Given this list of marker genes TRAPPC6A, TAB1, NEU1, GDF9, CDH17, CIPC, VPS4B, KLHL18, TXN2, CIT (NCBI Gene Id 11113), HNRNPUL2-BSCL2, GINS1, KHDRBS1, ACTL6A, ENSG00000260830, RUVBL1, EIF2B2, LINC02313, BTBD10, SP4, TNKS1BP1, SRP54, VPS39, TMEM170A, SLC26A2, UBE2Z, COPS5, PHF23, PPP1R13L, ANGEL2, PDE4A, CLCN3, ARFIP2, GPR63, PWWP2A, MRPL27, ZNRD2-DT, KDM4B, KLHL20 (kelch like family member 20), FAM83D, RNU6-1276P, KAZALD1, SMARCAD1, COLGALT1, SPNS1, PARK7, OSTC, DUS2 (dihydrouridine synthase 2), DDIT4, ZBTB22, CNEP1R1, TARDBP (TAR DNA binding protein), TOMM40L, FUZ, PCM1, RNH1, XPO1, CHD4, KBTBD4, GMNN, RPL10, MTARC2, PHF20, SUCLG1, SIRT4, SLC16A1-AS1, EXOSC8, SLC30A5, MTHFD2, DERL2, ATP5F1A, H2AC13, TAOK3, NAPRT, HNRNPUL2, GPR108 (G protein-coupled receptor 108), PCBP1, HSD11B1L, TSACC (TSSK6 activating cochaperone), TPI1P2, AP1M2, MBTD1, KPNA6, RBM15, WWP2, KCNIP2-AS1, SPRY4, ERH, MSL2, AP4M1, ZBTB3, GARIN5A, RNGTT, ZNF484, SGO1-AS1, ZNF823, SNAP23, CPSF2, ZSWIM4, GCLC, ACTN4, METTL15, LMAN2L, FGFR1OP2, SNRNP35, MED18 (NCBI Gene Id 54797), PMEL, H2AC25, TBP, ZNF785, TAMM41, STAG3L4, ZNF628-DT, BORA, DDX39B, RPAP3-DT, FBXL12, AFG1L, MKKS, FIBP, IL4I1, MVK, DHX34, EVI5L, MST1, SLC27A5, A2ML1, NFYA, GSPT1 (G1 to S phase transition 1), ACP6, PCK2, GABPA, MBOAT7, ZNF860, ZDHHC6, RNVU1-14, ORC2, FBXO8, FBXL18, AREG, SON, PARL, UTP18 (UTP18 small subunit processome component, NCBI Gene Id 51096), NOP16, HARBI1, FGD5-AS1, MTOR, TNPO3, HECTD1, DCTPP1, DDX39B-AS1, LINC02541, RNPS1, NT5C3A, AMN1, GAPDHP25, ELL3, H2AX, H2BC13, EPB41L5, IKZF4, NXN, PPP6R1, HAUS4, C15orf40, PPP2CA-DT, TIPARP, SPC25, DEPDC1B, ATP5MC3, LINC02363, NDUFA2, PSMD4, YARS1, RBM6, PRKCI, MEMO1, LINC02832, PDCD4, NDUFC1, TMEM87B, DUSP12, DNAJC27-AS1, H2AC11, SFSWAP, MIR762HG, FAM185BP, RRP15, POLG-DT, HOXA-AS3, AGAP2-AS1, POLR2H, LINC01089, TMEM208, TAGLN2, TARS1, R3HDM2-DT, ASTE1, MST1P2, DDIAS, RAB4B-EGLN2, TUBGCP6, HASPIN, CD164, NFATC4, TDRKH-AS1, PMS2P4 (PMS1 homolog 2, mismatch repair system component pseudogene 4), IER3-AS1, CDC37, DOHH, ZDHHC17, WDR74, ABHD17B, PBX3, WDR37, NUBP2, NOSIP, QTRT2, ITGA6-AS1, SLC52A3, POLR3A, CKAP5, RBM7, MAN1B1-DT, GNL1, STYX, DIAPH1-AS1, THBS4, CCNL1, AP1M1, RNU4-2, SMIM31, TIAL1, MAP4, BNIP1, TAX1BP1, SPRED2, MCTP2 (multiple C2 and transmembrane domain containing 2), SZT2, GART, RTRAF, UNC13D, DNMT1, PLSCR4, HMGB2, MPLKIP, HSP90B1 (NCBI Gene Id 7184), RGS5 (NCBI Gene Id 8490), FLOT1, MIS18BP1, UBE2D3, DNAJC27, TAF10 (TATA-box binding protein associated factor 10), EIF3D, VPS26B, NDUFS3, PRELID3BP5, LGALS8, CDIPT, RTN4 (reticulon 4), AK2, EDC3, PROSER1, TSPAN8, VCL, ABCA7, DDX20, BRPF1, SNX10-AS1, NCK1 (NCK adaptor protein 1, NCBI Gene Id 4690), DTWD1, STARD5, HBS1L, ATG4C, MBLAC2, METTL4, UPP1, PRKRIP1, MIR3677HG, CLASP1, TIMM21, ANKHD1, ANKHD1-DT, PSMD7, HSD17B4, TANC1, BORCS5, CASZ1, CLN3, PPP3CA, TOP2A, NDUFA6, PSMD8, CMSS1, RABGAP1L-DT, SOX2-OT, GHDC, FBXW7, PGS1, CDC20-DT, DPH5-DT, SND1-DT, TJP3, H4C2, SPAG5-AS1, KIF18A, SCAMP1, INTS13, NAA15, LIMA1, CCDC30 (coiled-coil domain containing 30), TULP3, RPUSD4, THAP7 (THAP domain containing 7), MTBP, EIF6, DRAIC, SPTLC2, TIMM22, FAM53C (family with sequence similarity 53 member C), SAR1A, MED17 (mediator complex subunit 17), DCP1A, AASDH, ATP5PF, SLC37A1, POLR2M, GTF2B, SMG5, SPSB3, FLAD1, DCLRE1A, ARPC5L, AKR1A1, IGFL2-AS1, TAS2R14, PIGO, WBP11, NR6A1, RAPGEF6, ABCF1, CENPF, NUCKS1, NCOR1, S100PBP, BANP, ANKRD27, HAUS5, MCCC1, ATF3, EIF3F (eukaryotic translation initiation factor 3 subunit F), CCDC9, ZNF446, LOH12CR2, CDCA2, EFHC1, NUP93, NCK1-DT, TMEM198B, NDUFB1, HSDL2, GON4L, ARMH1, QRICH1, KITLG, CAGE1, PSMC3, ARHGAP11A-DT, HNRNPL, MYCBP2, RPRD2, UGT2B7, SRRM2-AS1, ARNT, PLAC8, MYG1 (MYG1 exonuclease), COL17A1, IFNAR1, SETD1A, ACLY, EIF1, ENSA, CLINT1, VTRNA1-2, MAGI1, GRHPR, OXSR1, EME1, UBE2H, ABCA15P, ITFG2-AS1, TMEM218, CDK5, MFAP3, LRR1, ENSG00000268460, HIF1AN, DNAJC19 (NCBI Gene Id 131118), SCAMP2, RPAP3, SUGCT, UBOX5, SPATA17, GPR19, L3MBTL2, KCTD9, BLOC1S1, CRELD1, ANP32A, TXNDC12, TRIM37, BZW1, FADS1, MCTS1, FBXL9P, MOK, SPAG7, GGPS1, COA1, RAD51AP2, GRK6, POLG, CEP89, ZFC3H1, MIR4512, RBM15-AS1, H2AZ1-DT, MRPL24, CCT3, DUS4L, CCDC124, KIFC1, SNORA21, ADGRE2, LAMP1, FKBP2, MIR933, TRAPPC4, CEP350, MIR4999, INO80C, CSPP1, TPX2 (TPX2 microtubule nucleation factor), ILF3 (NCBI Gene Id 54783), ORMDL1, UBXN7, AIRIM, LMBRD1, FAAP24, GDAP1, ERP29, CLRN3 (clarin 3), TCP11L2, TUBA1B, ZNF584, UBALD2, CAPZA2, GIN1, PBX3-DT, ERAP1, H3C1, DHX8, RBM27, BUB1B, MRTFA, SPAG5, PSMD7-DT, PCGF1, ARMT1, CROCCP2, MXD3, DPH5, TMEM79, CDK13, SNORD12, BCL2L14, LEKR1, RHOQP1, RNF186-AS1, JARID2, ELOF1, LENG8-AS1, MRPL45P2, IER5, PSORS1C1, PUS1-AS1, ILF3-DT, FAM47E, PCLAF, LRP4-AS1, HMGCS1, RBMS2, INTS10, RGS9BP, RWDD1, KHSRP, RPL13A, CENPBD2P, CDCA7L, ZNF627, BRF1, SGO1, MEX3C, ARAP1, EWSR1, STARD10, ISOC2, UNC45A, CACTIN, NFATC2IP, RBAK, BUB3, QNG1, BTF3L4, FGFR4, MIR638, CCDC146, KRT8, DOCK8-AS2, HAX1, TMED4, OS9, STX3, EIF5A2, MEST, TBX3, CEP131, PEX12, USP35, SLC39A9, RPH3AL-AS2, PIGN, VTI1A, RBPJ, INTS2, SLC25A42, MRPL13, C12orf60, CDKN2C, ZNF48, EXOC8, FOXA3, NR2C2, LZIC, RPS29 (ribosomal protein S29), MINDY2-DT, LINC00649, TYW1B, SLC2A1, RAB11B, RPL36 (ribosomal protein L36), PRR15L, CMC2, VARS2, THUMPD3-AS1, KDM4C, HDAC5, IWS1, CENPE, MGAT1, RPS6, CCDC163, PDE11A, NDC80, TFPT, ADK, TMUB2, ATP6V0D1-DT, TOM1L2, TAF12, TDRKH, COX6C, TIPRL, NLK, ITPRIP (inositol 1,4,5-trisphosphate receptor interacting protein), CCDC192, ALG5, HEXA, C9orf85, GATAD2A, C14orf119 (chromosome 14 open reading frame 119), HGS, MZF1, ANAPC15, NHLRC3, ZNF786 (NCBI Gene Id 136051), LINC01023, RSRC1, ZNF398, TEF, MROH8, CCT6A, SNED1-AS1, H4C8, TOMM22-DT, ALDOA, IP6K1, VPS39-DT, TEX2, LENG8, ITPA, NPTN, USPL1, DCAF7, TMEM102, RBFA, WDR55 (WD repeat domain 55), TMEM202-AS1, ENC1 (NCBI Gene Id 8507), ALDH4A1, UGP2, FRAT1, ERCC1, LRPPRC, ATP6V0D1, CHM, PMF1-BGLAP, ZNF672, PSME2, CSNK2B, POMP, RABGAP1L, RPL5, MIA2-AS1, TMEM165, CLPTM1, B4GALT3, ELP2, UBE2B (ubiquitin conjugating enzyme E2 B), H2BC11, TMEM53, LRP10, R3HDM2, PRR3, PIH1D2, FAM13B, RIOK1, RPL30, TUFT1, RIC8B, EIF4G2, RIDA, ASCC1, KLHDC10, RPL22L1, PIK3R3, KCNIP2, POLR3G, MRPL49, GTF3C2-AS2, TMED1, SYNGR4, DNAH2, PPP4R3B-DT, MAPK7, DEPDC4, ZNF56P, KCTD7, ITGB8, USP53, TTC9C, CDC40, RGS16, H2AZ2-DT, PRORSD1P (prolyl-tRNA synthetase associated domain containing 1, pseudogene), THRAP3, TICRR, HYCC2, NDUFA3, CCDC191, ZWINT, MIA2, DMXL2, SPECC1, SEH1L, SLC30A9, MED8, TMEM143, EFNA4-EFNA3, UFD1, NGRN, KIF3B, SRP54-AS1, TIMM50, ZNF709, RPL7P30, ZNF514, NEAT1, COMMD6, RBAK-RBAKDN, PSMB10, CYTH2, ANKRD24, TUT7, ENSG00000275740, CDK12 (NCBI Gene Id 51755), ARHGAP19-SLIT1, UBP1, UBL3, PISD, MIR3678, PRCP, TMEM18, CARD8, NOCT (NCBI Gene Id 25819), TPK1, PLK2, BTF3-DT, PMS1, MTMR12, MMUT, PAK4, ABCF2, PFKM, HTD2, COG3, DDA1, CEP120, DDX59, EMP1, PSMD3, RSL24D1, GAR1-DT, TMT1B, SCP2, PLK1, NHLRC2, DMAP1, EIF2B5, PDE12, MARS2, PPOX, CDCA5, PKIA, XRCC2, ANKHD1-EIF4EBP3, CYRIB, POLR1G, NCOA3, HNRNPC, DRC3, ZNF747 (zinc finger protein 747), PPP1R15A, RN7SL688P, RSBN1 (NCBI Gene Id 54665), CBX8, SH3RF2, XAB2, OAZ2, WEE2-AS1, NDUFB3, ATG13, HYAL2, BDNF-AS, RSPH1-DT, SNORD59A, BTN2A1, DHX16, RPL27, SPRYD4, RNF139-DT, MTMR10, CDKN3, KAT6B, SUN1, E2F6, YWHAQ, SP2, ATP5PO, PABIR1, TYK2, SUPT16H, MMAB, INO80E, SSBP1, RAB3A, SNRPD2, CENPQ, ANAPC16, MFSD11, SLC39A6, RAB5B, RNF139, CCDC25, ARL6IP1, C18orf32, UTP3, TUBA1C, SLC50A1 (solute carrier family 50 member 1), RRM2, IK, INCENP, CISD3, SMARCAD1-DT, EXO1, HDGF, B3GALNT2, ANXA2R, FLCN, GAB1, WDCP, ZNF684, SCAF1, GIPC1, COX7A2L, ETFBKMT, RPSAP31, VAPA, KPNA2, HLA-E, MRPS15, RAD52, SIRT6, GTF2H4, FBXO15, MAN1B1, MRPS18C, STK19, CDKL3, ZNF184, IDI1, CLUAP1, POP1, C17orf100, SHC1, SHARPIN, TEDC1, RPS25, ASXL1, THAP2 (THAP domain containing 2), SRRT, CRIPT, SLC4A2, FASTKD5, FAM118B, ATL2, MPV17L2, ANAPC5, NUP88, ENSG00000254531, TUBA1B-AS1, STX12, RAB4B, HTT, POLM, SMAD7, LRRC41, ZDHHC12-DT, GNS, DPM3, GIT2, ITFG2, PSMB1, DCAF15, TARS1-DT, CD320, GALM, ILF2, BLCAP, UQCRH, NIT2, SNAPC5, C5orf15, ZNF2, UBE2C, CALR (calreticulin), RNF181, ZDHHC5, PCSK9, EFNA3, SH2D3C, EEPD1, ENSG00000232995, IFT52, CEP44, FOXP2, ZFYVE27, TRA2A, PET100, HIVEP1, ZBTB41, BSCL2, LMO7, MRPL1, PRR13P5, BTN3A1, IER2, DXO, AP3B1, MAVS, NDC1, PCBP1-AS1, STIM2, TXNL4A, ODAD4, CFAP69 (NCBI Gene Id 79846), MAPKBP1, TWNK, EFNA4, LAMA3, SDE2, ARL1, POC1A, PRKACA, UVSSA, SMC3, ZDHHC12, PHRF1 (PHD and ring finger domains 1), ABHD11, ANKMY2, NUF2, MDM4, CENPA, ST13, WASF1, PRH1, RPL23, DDX46 (DEAD-box helicase 46), KLHL26, STK35, UBE2D3-AS1, OSCAR, SNORD18A, HIRIP3, TSSC4, NMNAT1, SIKE1, SERP1, ZHX1-C8orf76, GLRX, CKS1B, CDKN1A, FBXO33, AIFM1, AP2B1, BTF3, ARRDC4, SECISBP2L, H2BC9, POLR3D, TMED2, SGF29, EIF4A2, PRKAG1, RPL30P11, MCM7, ATF7IP, RNF123, CENPN, WWP1, STARD4 (NCBI Gene Id 154899), PABPN1, ANGEL1, CFAP418, MIR4453HG, YEATS4, PPP1R37, CCDC125, NFE2L1-DT, WDR5B-DT, OARD1, SNORD15A, GPANK1, FBXO16, MTF2, SHC4, OASL, BCL6, PMF1, TOMM22 (NCBI Gene Id 56993), ADIPOR1 (adiponectin receptor 1), MICOS13, ITGA7, KANSL3, GEMIN5, C9orf43, SDHA, NKAPD1, SP1, UBN2, MIEF2, CENPU, CTDSPL2-DT, DCAF12, PRRG2, RFC3, LRP6, WDR43, NDUFA6-DT, PRDX1, RPL7L1P8, SRSF2, DLGAP5, DUT, AAAS, RAB11B-AS1, MRPL45, ZHX1, ST3GAL4, IQCD, GRB2, SYNCRIP, UBL5, PIF1, MVB12A, TXK, HNRNPAB, KDSR, MRPL15, PNRC2, KCTD21, SLC16A1, FUS, DCP1B, USP36, SYMPK, MRPL32, ZNF770, EMC10, JPT1 (Jupiter microtubule associated homolog 1), AATF, LTA4H, METTL16, IQGAP3, ASB16-AS1, DIAPH1, ARID4B, MIRLET7I, GPATCH2, LINC02889, CSNK1G1, SYVN1, OPA3, CDC20, RPS3, POLE3, TMA16, TIPARP-AS1, TMC3-AS1, TMEM126A, BRK1 (NCBI Gene Id 55845), OSBPL11, ARL4A, SMG9, NIFK-AS1, FKBP11, LGALS8-AS1, KIF9, TAF12-DT (NCBI Gene Id 105378616), WASF2, KANK1, SND1, TTLL13, OSBPL10, RAB5IF, NCAPD3, MINDY2, HTT-AS, SRRM2, TMX4, ENSG00000232876, SNORD16, FAM47E-STBD1, TGDS, TRAPPC9, ADAMTSL5, NASP, CNOT1, SBDSP1, RPL35, FXYD5, MIR4519, ZBTB40, ZC3H4, AGL, LINC00513, PEX5, RNPEP, TPCN1 (two pore segment channel 1), DOLPP1, THAP7-AS1, PPP1R3F, SBNO1, CCDC186, DNM2, B9D1, NARS1, GTF3C2, RABIF, RMND1, TSPAN31, LSM4, MOSPD3 (NCBI Gene Id 64598), PTPRK, RFX1, LINC02960, HJURP, CDC26, DNAJC14, FAU, DNM1P35, TMEM116, C6orf52, ALKBH2, BZW2, ENSG00000261335, PLK3, WDR5B, MAF1, H2BC26, IFRD2, ARL16, NFE2L1, PSMA2, H3C4, MTX3, RSU1, CDC45, FKBPL, MIRLET7IHG, ZNF775, GLUD1P2, NDUFA4, CDCA8, PIGM, OLMALINC, RNU6-1301P, CTDSPL2, LRRC23, TMEM39B, PRPF4, RPP14, PRR4, ZNF181, PIGF, PSMA4, PPIL3, NUP93-DT, CEP41, EID1, PPIP5K2, SAE1, ABHD2, RELCH, FAM220A, LINC01132, MRPL43, TMEM106C, EHF, SPRTN, ATF5, H3C7, ARMC8, ARF6, ZSCAN20 (NCBI Gene Id 96159), RNF31, ITGAE, GCN1, DNM1L, TMX4-AS1, PRCC, NEK2, NCL, PSPH, LINC02939, INKA2, FAM227B, TRIP10, PSMC3IP, OGA, PIGO-AS1, SLC11A2, QPCTL, XPOT, PPP4R3B (protein phosphatase 4 regulatory subunit 3B), STIM2-AS1, ATP5F1B, PRPF31, BLOC1S3, MIR320A, TMEM134, TMEM160, PITRM1, RPN2, NIF3L1, CKS2, GPRC5D-AS1, HELQ, JARID2-DT, MIS12, MLKL, COPG1, MAP3K8, C11orf71, ZBTB45, ZNF106, ENSG00000246308, GAR1, VAMP1, PPIL2, TSEN34, TAF15, MRPL54, HMGB1, SAMD4B, TIMM10B, ATOSB, FAM83C-AS1, SETD5, AQR, MMACHC, ADM, XPNPEP3, RPAIN, SCYL3, RGL2, SUB1, UQCRQ, C19orf38, USP30, BSDC1, LBR (lamin B receptor), TNFSF9, CFLAR, EXOC6B, SIN3A, ABCC10 (ATP binding cassette subfamily C member 10), ACSL1, TMEM192, RNU1-117P, MED31, RSPH1, HEXA-AS1, IRF2BP1, MXI1, SENP1, METTL2B, RHBDD3, ARHGAP11A, GFM1, MZT1, S100A11, SNORD84, DNMBP, CCDC134, FITM2 (fat storage inducing transmembrane protein 2), ZNF57, CCDC127, ZNF131, NDUFA11, JUP, EFCAB5, SCYL2, VPS18, NUP62, RPUSD3, CDIPTOSP, VMAC, HAUS5-DT, HIBCH, ALCAM, ZFPL1, LARS2, RN7SL521P, ATF2, CCDC15, H2AZ1, MAP3K7 (NCBI Gene Id 6885), PPP2CA, ARHGAP19, SH2B3, SKOR1-AS1, FAM114A2, LDLR, SAMD1, SLC28A2-AS1, PUS1, ZNF444, RPS8, FANCC, LACTB, POC5, ZNRD2 (zinc ribbon domain containing 2), POLR2A, SLX4IP, GIPR, HBP1, here is a description of the gene set: from publication Yevshin I, Sharipov R, Kolmykov S, Kondrakhin Y, Kolpakov F (PMID 30445619) Genes containing one or more binding sites for (BARX1) in their promoter regions (TSS -1000,+100 bp) as identified by GTRD version 20.06 ChIP-seq harmonization. studied in species Homo sapiens Human Gene Set: BARX1_TARGET_GENES